The following is a description of a gene set: Human Gene Set: GOBP_CARBON_DIOXIDE_TRANSPORT studied in species Homo sapiens The directed movement of carbon dioxide (CO2) into, out of or within a cell, or between cells, by means of some agent such as a transporter or pore., and this is the list of marker genes: HBG1, HBD, HBE1, HBB, HBZ (hemoglobin subunit zeta), HBG2, HBA1, RHBG, CA2, HBA2, RHAG, AQP5, AQP1, AQP6, RHCG